The following is a description of a gene set: This event has been computationally inferred from an event that has been demonstrated in another species.<p>The inference is based on the homology mapping from PANTHER. Briefly, reactions for which all involved PhysicalEntities (in input, output and catalyst) have a mapped orthologue/paralogue (for complexes at least 75% of components must have a mapping) are inferred to the other species. studied in species Mus musculus Reactome Pathway: Mitotic Metaphase/Anaphase Transition electronically inferred by orthology from the curated human pathway part of: Mitotic Metaphase and Anaphase, and this is the list of marker genes: Plk1